The following is a description of a gene set: Abnormality of dental color studied in species Homo sapiens Human Gene Set: HP_ABNORMALITY_OF_DENTAL_COLOR A developmental defect of tooth color., and this is the list of marker genes: FAM20A, KRAS, MYO7A (myosin VIIA), SLC24A4, ADGRV1, ALMS1, SLC13A5, ROGDI, UROD, COL17A1, HRAS, ENAM, CNNM4 (NCBI Gene Id 619531), PDZD7, USH2A, HMBS, KRT14, SATB1, KCNJ5, RELT, MMP20, ITGB6, WHRN, NRAS, GALNS, AMBN, UROS, ITGB4, GATA1, GLB1, DLX3, KCNJ2, DSPP, KLK4